The following is a description of a gene set: Genes down-regulated in peripheral blood mononuclear cell 7d vs 0d in adults (18-50) after exposure to FluMist, time point 7D. Comment: Molecular signature induced by LAIV vaccination. (a) Interferon (IFN)-related genes differentially expressed after LAIV vaccination studied in species Homo sapiens Human Gene Set: NAKAYA_PBMC_FLUMIST_AGE_18_50YO_7DY_IFN_SUBSET_DN Here we have used a systems biology approach to study innate and adaptive responses to vaccination against influenza in humans during three consecutive influenza seasons. We studied healthy adults vaccinated with trivalent inactivated influenza vaccine (TIV) or live attenuated influenza vaccine (LAIV). TIV induced higher antibody titers and more plasmablasts than LAIV did. In subjects vaccinated with TIV, early molecular signatures correlated with and could be used to accurately predict later antibody titers in two independent trials. Notably, expression of the kinase CaMKIV at day 3 was inversely correlated with later antibody titers. Vaccination of CaMKIV-deficient mice with TIV induced enhanced antigen-specific antibody titers, which demonstrated an unappreciated role for CaMKIV in the regulation of antibody responses. Thus, systems approaches can be used to predict immunogenicity and provide new mechanistic insights about vaccines. from publication Nakaya HI, Wrammert J, Lee EK, Racioppi L, Marie-Kunze S, Haining WN, Means AR, Kasturi SP, Khan N, Li GM, McCausland M, Kanchan V, Kokko KE, Li S, Elbein R, Mehta AK, Aderem A, Subbarao K, Ahmed R, Pulendran B (PMID 21743478), and this is the list of marker genes: IFITM2, CXCL1, CSNK1A1, PMAIP1, SOCS3, CXCL8, ICAM1, TRAF6, CDKN1B, OSM